The following is a description of a gene set: Mouse Gene Set: MIR_208A_3P_MIR_208B_3P from publication Chen Y, Wang X (PMID 31504780) studied in species Mus musculus Genes predicted to be targets of miRBase v22 microRNA mmu_miR_208a_3p, mmu_miR_208b_3p in miRDB v6.0 with MirTarget v4 prediction scores > 80 (high confidence targets)., and this is the list of marker genes: Kpna3, Macir, Med13, Hoxd3, Chd9, Stc1, Fnip1, Pgap1, Gins2, Cnot6l, Reep1, Lrrtm1, Ets1, Rgs17, Cdh2, Macroh2a1, Zxdc, Ube2v2, Nlk, Ube2v1, Slc39a3, Vav3, Sos2, Rps20, Mtf2, Gata4, Nin